The following is a description of a gene set: Reactome Pathway: ChAHP complex assembly part of: CHD3, CHD4, CHD5 subfamily In addition to acting monomerically or as part of various NuRD complexes, CHD4 also plays a role as a component of ChAHP1 and ChAHP2 complexes. These complexes also contain ADNP or ADNP2, respectively, along with a member of the CBX/HP1 family, and act to control expression of target genes, SINE and ERV elements. species: Homo sapiens, and this is the list of marker genes: H2AC4, CBX3, ADNP, H2BC13, H2BC12, H2BC11, H2AC20, H2AC7, H2BC4, H2BC5 (NCBI Gene Id 3017), H2AC6, H2AX, ADNP2, H2BC3 (H2B clustered histone 3), H2BC12L, H2AC18, H2AC14, H2AB1 (NCBI Gene Id 474382), H2BC9, H2BC26 (NCBI Gene Id 128312), H2BC1, H2BC14, H2AZ2, H3C1, CBX1, CHD4, H2BC21, H4C1, H2AJ, H2BC17, H2BC15, H3C15